The following is a description of a gene set: The aggregation, arrangement and bonding together of a set of components to form a postsynaptic membrane, a specialized area of membrane facing the presynaptic membrane on the tip of the nerve ending and separated from it by a minute cleft (the synaptic cleft). Mouse Gene Set: GOBP_POSTSYNAPTIC_MEMBRANE_ASSEMBLY species: Mus musculus, and this is the list of marker genes: Nlgn2, Nrxn1, Cdh2, Nlgn3, Nrxn2, Lrp4, Nlgn1, Magi2, Ephb2